The following is a description of a gene set: species: Homo sapiens FLT3 signaling by CBL mutants Human Gene Set: REACTOME_FLT3_SIGNALING_BY_CBL_MUTANTS, and this is the list of marker genes: RPS27A, FLT3, CBL, UBB, UBA52, UBC, FLT3LG